The following is a description of a gene set: Human Gene Set: GOBP_SIGNAL_TRANSDUCTION_IN_ABSENCE_OF_LIGAND studied in species Homo sapiens The series of molecular signals initiated by the absence of a ligand or the withdrawal of a ligand from a receptor., and this is the list of marker genes: IL7, KLF4, AKT1, HTRA2, BAX, STRADB, PPP1CA, NF1, TNF, INHBA, CX3CL1, MAP2K5, HSPA1B, CASP2, EYA4, CTNNA1, GPR62 (G protein-coupled receptor 62), BCL2, PF4, BCL2L11, FOXO3, ERBB3, IL1A, PRDX2, MAPK7, BOK, BCL2L1, C8orf44-SGK3, EYA3, SGK3, CSF2, PPP2R1A, FGFR1 (fibroblast growth factor receptor 1), COL2A1, ITGAV, BCL2L2, TGFB2, NRG1, BAD, NGF, IL1B, SNAI2, BCL2L10, MKNK2, FYN, TERT, GSK3B, BAG3, MOAP1, WWOX, BAK1, RIPK1, FADD, IFI6, EYA2, GATA1, IL2, EYA1, PPP2R1B, HSPA1A, GFRAL, FGF10, IGF1, BCL2A1, LCN2, GPR61, GDNF, RET, GSK3A, KITLG, MCL1, UNC5B, SRPX